The following is a description of a gene set: Mouse Gene Set: GOMF_METAL_ION_TRANSMEMBRANE_TRANSPORTER_ACTIVITY Enables the transfer of metal ions from one side of a membrane to the other. species: Mus musculus, and this is the list of marker genes: Nrxn2, Kcnt1, Tmem38b, Pkd1l3, Slc6a2, Slc13a1, Stx1a (NCBI Gene Id 20907), Slc8a1, Kcne2, Slc20a2, Slc23a1, Prss30, Cacng5, Slc13a2, Nipa1, Orai3, Stim1, Cav3, Tmem175, Kcnc3, Tfrc, Slc9a2, Slc23a2, Nrxn1, Grm2, Kcnn2, Nalcn, Trpc5, Grina, Slc30a9, Slc46a3, Slc12a5, Kcnmb2 (potassium large conductance calcium-activated channel, subfamily M, beta member 2), Itpr2, Kcnq2, Atp2a2, Atp2a3, Kcnk9, Cacna2d1, Orai1, Grik5, Slc39a4, Cnnm2, Slc4a9, Psen1, Ryr1, Glrx, Kcnk2, Atp12a, Kcnk12, Ywhae, Trpa1, Kcnj14, Cav1, Kcnab3, Akt1, Kcnj13, Zdhhc13, Slc10a5, Slc39a10, Micu3, Slc31a1, Kcns3, Mmgt2, Stimate, Kcnj3, Cnnm4, Kcnn3, Trpm5, Slc1a1, Cnga2, Kcnq4, Slc17a7, Kcng1, Slc39a12, Anxa5, Atp4b, Grik2, Trpc7, Tmem38a, Trpm7, Slc24a2, Slc6a8, Slc4a4, Abcc9, Gm5134, Slc13a4, Tmbim7, Kcnip4, Chp1, Asic2, Slc9a1, Trpv4, Slc8a3, Asic1, Kcnh6, Gpm6a, Slc24a3, Slc10a2, Slc30a1, Hamp2, Cacnb1, Trpv1, Ywhah, Itgav, Hamp, Kcnd1, Kcnh5, Cacna1h, Slc25a37, Gem, Ank2, Ccdc51, Lrrc52, Tspan13, Mfsd2a, Kcne1, Scn10a, Calhm1, Kcnj9, Kcna4, Fgf12, Slc30a7, Nalf1, Pkd1, Slc13a3, Slc39a14, Cacng2, Kcna3, Slc18a1, Wnk4, Pde4d, Dlg1, Slc17a8, Atp2b1, Kcnd2, Bnip1, Lrrc38 (NCBI Gene Id 242735), Cacna2d2, Cacna1g, Kcnmb1, Tmem168, Grin2b, Slc5a7, Tspoap1, Kcnk15, Fgf14, Slc12a6, Trpm1, Slc38a7, Htr1b, Kcna1 (potassium voltage-gated channel, shaker-related subfamily, member 1), Scn1a, Kcnb1, Nos1, Calm1, Scn4a, Nalf2, Fxyd4, Cabp4, Flna, Tusc3, Slc5a6, Sumo1, Fkbp1b, Lrrc55, Slc39a13, Calm2, Cacna1f, Scn1b, Nipal2, Scn5a, Pacsin3, Slc34a2, Dpp10, Kcnh7, Kcnj12, Kcng4, Cacna1c, Slc24a5, Slc10a1 (NCBI Gene Id 20493), Kcnd3, Scnn1a, Atp2b2, Scnn1g, Cabp1 (calcium binding protein 1), Atp2c2, Atp7b, Atp1a2, Trpm3, Cacna1b, Slc22a5, Slc5a3, Slc39a9 (solute carrier family 39 (zinc transporter), member 9), Nrxn3, Nipal4, Slc30a8, Kcnn4, Nipal3, Slc38a5, Cacng1, Rimbp2, P2rx1, Slc5a4b, Slc6a14 (NCBI Gene Id 80646), Slc39a3 (NCBI Gene Id 208667), Atp1a3, Slc4a8, Cacna1e, Fxyd6, Slc4a7, Cacng3, Atp2b3, Slc9a5, Mcu, Sgk2, Cabp2, Lrg1, Tpcn1, Scn2a, Slc28a2, Cacna2d3, Pias3, Grik3, Mcoln3, Slc31a2, Slc9a4, Slc6a15, Slc41a1, Fgf11, Kcnu1, Pkd2, Cacnb3 (calcium channel, voltage-dependent, beta 3 subunit), Atp4a, Wnk3, Atp1a4, Slc5a2, Slc10a3, Aqp1, Slc24a4, Kcnk4, Kcnh8, Gria1, Cacng8, Scn2b, Slc17a6, Arpp19, Slc38a1 (solute carrier family 38, member 1), Slc39a5, Kcnj11, Cacnb2, Agt, Atp2b4, Kcnh1, Itpr1, Snta1 (NCBI Gene Id 99348), Sgk1, Grin3b (NCBI Gene Id 170483, glutamate receptor, ionotropic, NMDA3B), Slc5a5, Slc5a12, Trpc3, Kcng2, Scn3a, Trpc6, Cacna1d, Asic4 (acid-sensing ion channel family member 4), Slc12a7, Mcub, Micu2, Slc39a2, Grik4, Slc10a6, Atp2a1, Kcne5, Slc30a3, Nipal1, Tmbim4 (NCBI Gene Id 68212), Kcnv1, Gnb2, Cacng4, Kcnip1, Slc1a7, Rasa3 (NCBI Gene Id 97473), Kcnn1 (potassium intermediate/small conductance calcium-activated channel, subfamily N, member 1), Cacnb4, Slc5a1, Tnni3, Kcnip2, Kcnk10, Grm3, Letm1, Fxyd3, Pcsk9, Slc28a3, Trpc1, Faim2, Slc30a6, Kcnf1, Tmem94, Slc12a1 (NCBI Gene Id 99066), Cpox, Kcnj2, Slc12a3, Kcnj1 (potassium inwardly-rectifying channel, subfamily J, member 1), Kcne3, Slc9a3, Grik1, Cacng6, Hpcal4, P2rx7, Pkd1l2, Slc30a2, Kcnk7, Kcnk18, Slc39a11, Kcnh2, Grin1, Slc6a12, Cacna1a, Tmc1, Trpv2, Slc10a4, Prss8, Slc11a1, Kcna7, Catsper2 (NCBI Gene Id 212670), Trpm8, Calhm3, Slc24a1, Atp13a4, Tmprss3, Slc12a2, Slc10a4-ps, Slc34a1, Gria3, Atp1b2, Slc8b1, Slc1a6 (NCBI Gene Id 20513), Kcnt2, Slc38a2, Kcnv2, Scn8a, Magt1, Adrb2, Slc39a1, Slc6a3, Cnga1, Gpd1l, Slc12a8, Slc5a4a, Kcna5, Kcnh3, Slc9a8, Kcnmb4, Hcn4, Kcnq3, Trpc4, Slc28a2b, Slc9a7, Nipa2, Slc5a11, Itpr3, Grin2d, Slc12a4, Amigo1, P2rx4 (NCBI Gene Id 52272), Slc6a1, Slc12a9, Kcnab1, Rrad (Ras-related associated with diabetes), Panx1, Ghitm, Wnk2, Dpp6, Mcoln1, Pkdrej, Tmbim6, Trpv3, Hcn2, Akap9, Slc6a13, Ryr2, Asic5, Kcnk6, Kcns2, Slc5a10, Tmbim1, Kcnma1, Scn9a, Slc4a11, Kcnmb3, Atp1a1, Prkg1, Slc9a9, Slc39a6, Atp1b3, Kcnj5, Prkcb, Kcnk3, Sclt1, Scnn1b (NCBI Gene Id 20277), Micu1, Ptpn3, Ano9, Gria2 (glutamate receptor, ionotropic, AMPA2 (alpha 2)), Kcnh4, Slc25a28, Catsper3, Slc6a20a, Panx3, Slc6a6, Slc6a9, Stim2, Mcoln2, Kcna6, Rem1, Mrs2, Kcnj4, Kcnj15, Fxyd7, Nedd4, Slc5a9, Slc30a4, Tpcn2, Kcnq1, Slc9b2, Fxyd2, Hrh1, Rangrf, Slc30a10 (NCBI Gene Id 226781), Nedd4l, Gpld1, Catsper1, Kcna10, Slc6a4, Slc9a6, Lrrc26, Cacna1i, Slc22a1, Atp1b1 (NCBI Gene Id 11931), Slc8a2, Mmgt1, Sgk3, Slc4a10, Kcns1, Kcnk13, Slc41a3, Tmco3, Kcnj10, Cachd1, Fgf13, Tmco1, Slc6a7, Cacna1s, Fxyd1, Slc30a5, Slc38a3, Crisp4, Kcnip3, Calm3, Slc18a2, Tmem37 (NCBI Gene Id 98701), Slc38a4, Rem2, Trpm6, Cnga3, Oprm1, Cacna2d4 (calcium channel, voltage-dependent, alpha 2/delta subunit 4), Trpc2, Slc13a5, Snap25, Grm7, Kcnc4, Ryr3, Kcng3, Grin2c, Kcnc2, Scn4b, Kcnj16, Slc6a5, Prkcz, Slc9c1, Trpm4, Kcnq5, Slc29a1, Tmc2, Slc39a8, Cabp5, Scn7a, Kcnb2, Atp7a, Slc11a2, Kcna2, Orai2, Abcc8, Wnk1 (WNK lysine deficient protein kinase 1), Sec61a1, Fxyd5, Hcn1, Slc20a1, Slc34a3, Pkd2l1, Slc40a1, Kcnab2, Catsper4 (cation channel, sperm associated 4), Slc5a8, Ncs1, Kcnk1, Trpm2, Slc1a2, Phpt1, Slc28a1, Pkd2l2, Hcn3, Atp2c1, Slc6a11, Pkd1l1, Slc1a3, Grin3a, Slc39a7, Scn11a, Tmem165, Camk2d, Asic3, Grin2a, Slc22a3, Slc4a5 (solute carrier family 4, sodium bicarbonate cotransporter, member 5), Trpv6, Kcnj6, Ensa, Kcne4, Scn3b, Kcnk16, Commd1, Cacng7, Trpv5, Slc6a18, Kcnj8 (potassium inwardly-rectifying channel, subfamily J, member 8), Slc6a20b, Kcnk5, Kcnc1